Given this list of marker genes ATPAF1, FMC1, ATP5F1D, ATP23, OXA1L, TMEM70 (transmembrane protein 70), ATPAF2, TMEM242, here is a description of the gene set: Human Gene Set: GOBP_MITOCHONDRIAL_PROTON_TRANSPORTING_ATP_SYNTHASE_COMPLEX_ASSEMBLY The aggregation, arrangement and bonding together of a proton-transporting ATP synthase in the mitochondrial inner membrane. species: Homo sapiens